The following is a description of a gene set: Human Gene Set: GOBP_CORNIFICATION species: Homo sapiens A type of programmed cell death that occurs in the epidermis, morphologically and biochemically distinct from apoptosis. It leads to the formation of corneocytes, i.e. dead keratinocytes containing an amalgam of specific proteins (e.g., keratin, loricrin, SPR and involucrin) and lipids (e.g., fatty acids and ceramides), which are necessary for the function of the cornified skin layer (mechanical resistance, elasticity, water repellence and structural stability)., and this is the list of marker genes: CYP26B1, CASP14, CDSN, LIPM, TMEM79, LIPK (NCBI Gene Id 648156), KLK5, LIPN, CERS3